The following is a description of a gene set: Human Gene Set: HP_ORAL_AVERSION Oral aversion Reluctance or refusal of a child to be breastfed or eat, manifested as gagging, vomiting, turning head away from food, or avoidance of sensation in or around the mouth (i.e. toothbrushing or face-washing). studied in species Homo sapiens, and this is the list of marker genes: SMARCB1, SMARCA4, PACS1, SMARCE1, SOX4, SOX11, ARID1A, SMARCD1, CRELD1, SMARCC2, ARID1B, GRB10, ARID2, DPF2, ACAT1, SLC7A7, MEIS2